Given this list of marker genes Gata2, Il25, Stat5a, Il5, Trib1, Lyn, Gata1, here is a description of the gene set: The process in which a relatively unspecialized myeloid precursor cell acquires the specializes features of an eosinophil. studied in species Mus musculus Mouse Gene Set: GOBP_EOSINOPHIL_DIFFERENTIATION